The following is a description of a gene set: In this study, an extensive analysis was conducted to define meta-programs (MPs) capturing intra-tumor heterogeneity across a spectrum of tumor types. The approach utilized non-negative matrix factorization (NMF) to analyze each cell type separately within individual tumor samples. This involved the analysis of malignant cells, macrophages, fibroblasts, endothelial cells, epithelial cells, T-cells, and B-cells. NMF was executed with varying parameter values (K=4, 5, 6, 7, 8, 9), thereby generating 39 programs for each cell type per sample. Each NMF program was summarized by the top genes based on NMF coefficients.\nRobust MPs were then delineated for each cell type using a set of stringent criteria, including recurrence within the same tumor, similarity to programs in other tumors, and non-redundancy within a tumor. Subsequently, these robust NMF programs were clustered (per cell type) based on Jaccard similarity, leading to the identification of MPs associated with each cell type.\nTo enhance the quality of the MPs, a refinement steps were undertaken, involving the removal of MPs suspected of reflecting low-quality data (with an overrepresentation of ribosomal proteins or mitochondrial-encoded genes), single-study inclusion, or similarity to miss-annotated cell types. from publication Gavish A, Tyler M, Greenwald AC, Hoefflin R, Simkin D, Tschernichovsky R, Galili Darnell N, Somech E, Barbolin C, Antman T, Kovarsky D, Barrett T, Gonzalez Castro LN, Halder D, Chanoch-Myers R, Laffy J, Mints M, Wider A, Tal R, Spitzer A, Hara T, Raitses-Gurevich M, Stossel C, Golan T, Tirosh A, Suvà ML, Puram SV, Tirosh I (PMID 37258682) Human Gene Set: GAVISH_3CA_MALIGNANT_METAPROGRAM_8_PROTEASOMAL_DEGRADATION studied in species Homo sapiens Genes upregulated in subsets of cells of a given type within various tumors, and this is the list of marker genes: PSME2, PSMD13, PCMT1, NQO1, NUP37, PRMT1, PSMB6, SSB, HSPA5, CDC123, ANXA1, EIF4A3, MCTS1, DDX39A, ILF2, SNRPB2, PDHA1, PSMC4, PSMB1, NDUFA9, TUBB4B, PGK1, CCT7, MDH1, GSTO1, DPM1, PRDX2, EIF3I, PSMC2, CCT8, PDIA3, SPCS2, IMPDH2, CCNB1 (cyclin B1), CCT5, NDUFS2, SSBP1, DCAF13, PSMA4, XRCC6, PRDX1, RTCB, POLR2G, ECH1, MRPL13, PSMA3, SLC3A2, PSMB3, LAPTM4A (NCBI Gene Id 9741), EIF4A1